Given this list of marker genes SPON1, TNF, CSNK1E, MIR15B, RTN2, GGA3 (NCBI Gene Id 23163), BIN1, IFNGR1, SP1, ABCA7, MIR103A1, FLOT2, MIR29A, MIR206, MIR16-1, LYN, TMED10, EPHA4, SLC2A13, LRRTM3 (NCBI Gene Id 347731), NTRK2, IGF1, PICALM, ABCA2, SORL1, MIR107, MIR455, RTN4, RANBP9, MIR29C, GSK3A, HAP1, MIR153-1, GSAP, APOE, FKBP1A, IFNG, AGER, ROCK1, APP, ABCG1, MIR24-1, DYRK1A, CASP3, PIN1, MIR15A, CHRNA7, PRNP, RTN3, MIR298, MIR361, ROCK2, RELA, EFNA3, EFNA1, MIR339, MIR29B1, CLU, RTN1, MIR186, here is a description of the gene set: Human Gene Set: GOBP_REGULATION_OF_AMYLOID_PRECURSOR_PROTEIN_CATABOLIC_PROCESS Any process that modulates the frequency, rate or extent of amyloid precursor protein catabolic process. species: Homo sapiens